Given this list of marker genes PSMB5, PSMA5, CCNA1 (cyclin A1), PSMC1, ANAPC7, CDC27, ANAPC2, CDC23, PSMC6, ANAPC4, FZR1, ANAPC15 (NCBI Gene Id 25906), PSMD12, BTRC, PSMD3, PSMD7, UBE2S, UBC, PLK1, ANAPC1 (anaphase promoting complex subunit 1), PSMC2, PSMA4, CCNB1, PSMB1, PSMB7, PSMB2, UBE2C, FBXO5, PSMD8, BUB3, SKP1, PSMA6, UBE2E1, CCNA2, PSMC3, ADRM1, CUL1, ANAPC11, PSMD1, CDK2, PSMC4 (NCBI Gene Id 5704, proteasome 26S subunit, ATPase 4), PSMB6, SEM1, PSMB3, ANAPC10 (anaphase promoting complex subunit 10), CDK1, RPS27A, PSMA1, UBE2D1, PSMD2, PSMD13, ANAPC16, PSMC5, ANAPC5, MAD2L1, PSMB4, BUB1B, CDC20, UBA52, CDC16, PSMA2, PSMA3, PSMD14, CDC26, UBB, PSMA7, PSMD6, PSMD11, here is a description of the gene set: species: Homo sapiens part of: APC/C-mediated degradation of cell cycle proteins The APC/C is activated by either Cdc20 or Cdh1. While both activators associate with the APC/C, they do so at different points in the cell cycle and their binding is regulated differently (see Zachariae and Nasmyth, 1999). Cdc20, whose protein levels increase as cells enter into mitosis and decrease upon mitotic exit, only associates with the APC/C during M phase. Cdh1 associates with the APC/C in G1. This interaction is inhibited at other times by Cdk1 phosphorylation. Reactome Pathway: Regulation of APC/C activators between G1/S and early anaphase